The following is a description of a gene set: Reactome Pathway: Variant SLC6A20 affecting neurotransmitter transport contributes towards hyperglycinuria (HG) and iminoglycinuria (IG) part of: SLC transporter disorders SLC6A20 encodes the sodium- and chloride-dependent transporter SIT1 and mediates the sodium-dependent uptake of imino acids such as L-proline, N-methyl-L-proline and pipecolate as well as N-methylated amino acids and glycine (Broer & Gether 2012, Schweikhard & Ziegler 2012). The human protein is expressed in the intestine and kidney. A common SNP in the SLC6A20 gene, a 596C-T transition that results in a thr199-to-met (T199M) substitution can contribute towards iminoglycinuria (IG; MIM:242600) or hyperglycinuria (HG; MIM:138500). Overall, mutations in SLC36A2 together with polymorphisms in the modifiers SLC6A20, SLC6A18, and SLC6A19 constitute the genetic basis for these phenotypes. species: Homo sapiens, and this is the list of marker genes: SLC6A20